Given this list of marker genes Gja5, Coro2b, F2rl1, Ptpro, Gas6, Uts2r, Cyba, Ttr, Pdgfb, Uts2, Gja1 (gap junction protein, alpha 1), Adora1, Emp2, F2r, here is a description of the gene set: Any process that modulates the frequency, rate or extent of glomerular filtration. Glomerular filtration is the process in which blood is filtered by the glomerulus into the renal tubule. species: Mus musculus Mouse Gene Set: GOBP_REGULATION_OF_GLOMERULAR_FILTRATION